The following is a description of a gene set: Genes having at least one occurrence of the motif GRGAAAMBBWCAGS in the regions spanning 4 kb centered on their transcription starting sites. This matches the PTF1A transcription factor binding site V$PTF1BETA_Q6 (v7.4 TRANSFAC). species: Homo sapiens Human Gene Set: PTF1BETA_Q6, and this is the list of marker genes: RASSF2, HOXB6, ICMT-DT, LRCH4, ACVR2A, PCDHGC3, CA7, TREX2 (NCBI Gene Id 11219), HOXB4, TENT5A, MACROD2, NOL4L, ATP1B3, FOXO3, AFF3, LPL, FERMT2, ANAPC15, PANK3, DUSP22, ST18, FOXP2, CAPG, CDH13, BPIFB3, KLF13, ERBB3 (NCBI Gene Id 619500), ANK3, SOX4, MTMR4, EEF1A2, TMPRSS2, TBCC, DCAKD, AGBL2, STARD13, LIF, ZC3H18, HEATR9, DLG4, BBOX1, FGF14, REPIN1, MAGED1, TNIP2, HHIP, CRK, UBTF, VPS37B, H1-0, NR4A2, NMT1, ARMCX3, TBC1D10B, PCDH7, ITSN2, RELB, FBXW4, DHRS3, VAX1, NPPA, HCP5, TMTC2, CRHR1, ETV6, TRERF1, TFAP2A, PHYHIP, DMD, TEAD1, SRRM4, EIF4G1, KLHL24, FBXO24, CDK6, TBL1X, MECOM, LRRN2, LRRTM4, TCHP, KCTD15, PMP22, STOML2, SLC25A13, STC1, SYT3, ROR1, SLITRK3, CREBRF, SLC8A3, HOXD12, PUM1, TSHZ2, XPR1, YWHAE, GNAT1, PTBP2, HOXA11, ZIC1, PLXNC1, ZIC3, SLC25A14, LPCAT3, CTCF, CD6, NME3 (NME/NM23 nucleoside diphosphate kinase 3), LRRC49, GNG3, CITED1, ITPKC, PURA, ZFP36L1, AR, DNMT3A, TRAF4, PPARGC1A, THRA, COA3, MATN1 (NCBI Gene Id 4146), COQ8B, NXPH3, REST, CALD1, LRRTM1, KRT14, IGFBP6, PPP2R2A, COLCA1, THAP10, SLITRK5, SNCAIP, BSCL2, CELA1, HMGB3, RIF1, ZNF143, WBP1L, ITGB7, GAPDH, SLC6A14, RBSN, CD274, TGFB3, ZNF521, HES7, BCL2, ZBTB7A, CD163, HEBP2, GPC6, SYT7, RALYL, LRRFIP1, KCNJ1, DYNLL1, ABI3BP, CHD2, CYP1B1-AS1, ARMC8, RIMS1, OBSCN, EED (NCBI Gene Id 8726), NTRK1, WNK1, SMOC1, SMAD6 (SMAD family member 6), CCNC, FASTK, CACNA1C, LRRFIP2, GABRA1, CCKBR, EVA1B, RUSC1-AS1, ZBTB20, SMARCA2, PCDH17, MAP4, GATA6, ITGA7, SBF2, USP5, PAX3, IL1RAPL1, ICMT, MAN2C1, LINC01106, KIRREL2, STAT5A, PIAS2, FCHSD2, KDM3B, DICER1, CLVS1, AMMECR1, SRGAP2, PTPN2, SLC44A1, LIN28A, EMP3, PRSS3, CNTD1, CCN4, KMT2E, BAD, GPR162, MARCKSL1, CCDC140, PDE10A (phosphodiesterase 10A), ANKRD17, GSPT1, RASA1, TBL1Y, TNFRSF1A (TNF receptor superfamily member 1A), CASK, DDX17, ASIC3, ARHGAP30, FBXO40, FHDC1, ACADVL, MED13, ZC3H11A, BCL2L1, NCALD, XPO1, LINC00649, ARF3, NR4A3, TFAP2D, TSPYL2, KCNE5, SERBP1, RBM14, ZNF711, NPDC1, MPC2, TWF1, CSNK1E, MTTP, SLITRK1, PAQR4, APBA1, MSL2, IMPDH1, ROBO1